Given this list of marker genes FOXL1, MAP1B, CHGA, GNB4, STXBP6, GSDMA, KLHDC8A, ODAPH, ALDH7A1, GNB1, CDK12, RBPJL, BFAR, NT5DC1, WFDC8, PDPN, FLG2, WWP2, ADAM28, DCAF17, GSG1L, SIMC1, NHLH2, IL21, PPEF2, SEPTIN8, VWA8, PRELID2, TSGA10, here is a description of the gene set: Human Gene Set: MIR5191 species: Homo sapiens Genes predicted to be targets of miRBase v22 microRNA hsa-miR-5191 in miRDB v6.0 with MirTarget v4 prediction scores > 80 (high confidence targets). from publication Chen Y, Wang X (PMID 31504780)